The following is a description of a gene set: A wide pore channel activity that enables a direct cytoplasmic connection from one cardiomyocyte to an adjacent cardiomyocyte. The gap junction passes electrical signals between the cells contributing to cardiac conduction. studied in species Homo sapiens Human Gene Set: GOMF_GAP_JUNCTION_CHANNEL_ACTIVITY_INVOLVED_IN_CARDIAC_CONDUCTION_ELECTRICAL_COUPLING, and this is the list of marker genes: GJA1, GJD3, GJC1, GJC3, GJA5